The following is a description of a gene set: Reactome Pathway: Caspase activation via extrinsic apoptotic signalling pathway Caspases, a family of cysteine proteases, execute apoptotic cell death. Caspases exist as inactive zymogens in cells and undergo a cascade of catalytic activation at the onset of apoptosis. Initiation of apoptosis occurs through either a cell-intrinsic or cell-extrinsic pathway. Extrinsic pathway cell death signals originate at the plasma membrane where:<ul><li>An extracellular ligand (e.g., FasL) binds to its cell surface transmembrane “death receptor” (e.g., Fas receptor), inducing oligomerization of the receptor. The "death receptors" are specialized cell-surface receptors including Fas/CD95, tumor necrosis factor-alpha (TNF-alpha) receptor 1, and two receptors, DR4 and DR5, that bind to the TNF-alpha related apoptosis-inducing ligand (TRAIL). Ligand binding promotes clustering of proteins that bind to the intracellular domain of the receptor (e.g., FADD, or Fas-associated death domain-containing protein), which then binds to the prodomain of initiator caspases (e.g.caspase-8 or -10) to promote their dimerization and activation. Active caspase-8/-10 can then directly cleave and activate effector caspases, such as caspase-3 or it can cleave Bid, which facilitates mitochondrial cytochrome c release.</li><li>Unique group of proteins termed dependence receptors (DpRs) transduce positive (often prosurvival or progrowth) signals when engaged by ligand, but emit proapoptotic signals in the absence of ligand. DpR family includes p75 neurotrophin receptor (p75NTR), deleted in colon cancer (DCC), and UNC5 homologs, among others. cell-surface membrane receptors.</li></ul> studied in species Homo sapiens part of: Apoptosis, and this is the list of marker genes: RIPK1, ORF71, DAPK2, FADD, MC159L, MAGED1, TNFSF10, FAS, CASP9 (NCBI Gene Id 842), TLR4, CASP8, DAPK3, TNFRSF10A, CD14, TICAM1, TRAF2, CFLAR, UNC5A, CASP3, TICAM2, LY96 (NCBI Gene Id 23643), FASLG, DCC, UNC5B, TRADD, DAPK1, TNFRSF10B, APPL1